Given this list of marker genes GSK3B, RFX3, GATA6, MIR541, SOX9, ILDR2, BMP5, RHEB (NCBI Gene Id 6009), FOXF1 (NCBI Gene Id 2294), PDX1, BMP6, WNT5A, INSR, RBM4, NPHP3, IHH, CCDC40, PAX6, CTNNB1, CDK6 (cyclin dependent kinase 6), HES1, ZIC3, AKT1, GIP, PROX1, CDH2, CELA1, INSM1, SMAD2, SHH, MEIS2, HNF1A, GIPR, NR5A2, ALDH1A2, PDPK1, FGF10, PAX4, CLOCK, BAD, BMAL1, XBP1, MET, NKX2-2, GSK3A, BHLHA15, SOX4, NKX3-2, CCDC39, NKX6-1, SMO, IER3IP1, ISL1, IL6R, IGF2, DNAAF1, WFS1, IGF1, DLL1, ONECUT1, SELENOT, ONECUT2, FOXA2 (NCBI Gene Id 3170), TCF7L2, HNF1B, BAK1, PTF1A, RFX6, SRP54 (signal recognition particle 54), EIF2AK3, IL6, MNX1, NEUROD1, ZNF800, NKX6-2, BMP4, ACVR2B, SIDT2, WLS, GDF11, ZNF808, here is a description of the gene set: Human Gene Set: GOBP_PANCREAS_DEVELOPMENT species: Homo sapiens The process whose specific outcome is the progression of the pancreas over time, from its formation to the mature structure. The pancreas is an endoderm derived structure that produces precursors of digestive enzymes and blood glucose regulating hormones.